The following is a description of a gene set: species: Homo sapiens Human Gene Set: chr12q23, and this is the list of marker genes: WASHC4, ENSG00000257545, RNU7-94P, AMDHD1, TMPO-AS1, RPL18AP3, EID3, ENSG00000302820, HCFC2, CDK17, IKBIP (IKBKB interacting protein), RNU6-1068P, RN7SL88P, WSCD2, PARPBP, RPS4XP1, ELK3 (NCBI Gene Id 2004), TMPO, ISCU, TMEM119, GAS2L3, SLC9A7P1, RNA5SP371, ALDH1L2, LINC02452, C12orf42-AS1, ACTR6, ENSG00000300812, MIR1251, POLR3B, RNA5SP367, APPL2, GNPTAB, KRT18P20, CHPT1, ASCL4, MIR3922, RNA5SP366, NEDD1, GOLGA2P5, NUAK1 (NCBI Gene Id 9891), LINC02385, SYCP3, DRAM1, RNA5SP369, MIR3652, ABTB3, FICD, NT5DC3, RN7SKP11, NOPCHAP1, SETP7, RN7SL176P, CFAP54, HAL, C12orf75-AS1, ANKS1B, UQCC6, TMEM263, ARL1, PPIAP8, C12orf75, RMST, ENSG00000200897, CASC18, IGF1, SNRPF-DT, ENSG00000307169 (NCBI Gene Id 124902990), GLT8D2, CRY1, RNU6-1183P, ENSG00000296019, C12orf42, RNU4-24P, SNX5P2, ASCL1, RPS27P23, BLTP3B-DT, BLTP3B, LTA4H, CMKLR1, RNU4-41P (NCBI Gene Id 106481184), EEF1A1P33, PMCH, SNORA53, SCYL2, RN7SL793P, CCDC38, RNU6-36P (RNA, U6 small nuclear 36, pseudogene), ST13P3, RFX4, MIR1827, MIR135A2, RNA5SP370, LINC02453, TDG, ENSG00000258308, EEF1B2P4, SLC41A2, RPL17P38, ENSG00000212594, RNU6-768P, HELLPAR (HELLP associated long non-coding RNA), ANO4, GARIN6, TMEM263-DT, RNU5E-5P, LINC02456, PAH, ENSG00000258039 (NCBI Gene Id 101928937), HSP90B1, NR1H4, DEPDC4, RNA5SP368, MIR4495, TTC41P, LINC02409, LINC01498, SART3, LINC02401, ENSG00000257732, STAB2, PAFAH1B2P2, MYBPC1, SLC5A8, SPIC, RIC8B, MIR4303 (microRNA 4303), NUP37, RNY1P16, CKAP4, PWP1, TXNRD1, CHST11, LINC00485, SNRPF, YPEL5P3, PRDM4, UTP20, RNU6-172P, PRDM4-AS1, TCP11L2 (t-complex 11 like 2), SLC17A8, RNU6-101P, NENFP2, WASHC3, PIGAP1, NFYB, HSPE1P4 (heat shock protein family E (Hsp10) member 1 pseudogene 4), MTERF2, ENSG00000298892, APAF1, RPL30P12, SLC25A3